The following is a description of a gene set: Mouse Gene Set: MIR_28A_5P species: Mus musculus from publication Chen Y, Wang X (PMID 31504780) Genes predicted to be targets of miRBase v22 microRNA mmu_miR_28a_5p in miRDB v6.0 with MirTarget v4 prediction scores > 80 (high confidence targets)., and this is the list of marker genes: Sde2, Notch1, Ssrp1, Dpysl4, Tmem88, Nav1, Rcvrn, Rps24, Slc44a5, Wbp4, Garre1, Tmem127, Aak1, Tns3, Mmp15, Lurap1l, Rnf186, Sbspon, Gpm6a, Chl1, Drg2, Foxj3, Cbfa2t3, En2, Vrk3, Uba1y, Zfp961, Pitpna, Rplp0, Ezh1, 6030498E09Rik, Tmigd3, Arih1, Zfp352, Dkk3, Mta3, Amph, Ndrg2, Shprh